The following is a description of a gene set: Human Gene Set: GOBP_RESPONSE_TO_GROWTH_HORMONE species: Homo sapiens Any process that results in a change in state or activity of a cell or an organism (in terms of movement, secretion, enzyme production, gene expression, etc.) as a result of a growth hormone stimulus. Growth hormone is a peptide hormone that binds to the growth hormone receptor and stimulates growth., and this is the list of marker genes: JAK3, GH2, GHSR, STAT5A, JAK2, HNF4A, AKT1, LEPROT, MBD5, JAK1, PNPT1 (NCBI Gene Id 87178), CACYBP, PTPN1, STAT3 (signal transducer and activator of transcription 3), CSF2RA, GHRL, CPS1, CSH2, TYK2 (tyrosine kinase 2, NCBI Gene Id 7297), SHOC2, LYN, PHEX, PIK3R1, SRD5A1, STAT5B, TRIM16, STAT6, SOCS2, GH1, IGFBP5, GHR, PTK2, IGF1, F7, PXN, SLC34A1 (solute carrier family 34 member 1), HMGCS2, ASS1, GDF15, CSHL1, CSH1, LEPROTL1